The following is a description of a gene set: species: Homo sapiens Binding to a small protein activating enzyme, such as ubiquitin-activating enzyme. Human Gene Set: GOMF_SMALL_PROTEIN_ACTIVATING_ENZYME_BINDING, and this is the list of marker genes: PARK7, SAE1, SUMO1, UBE2I, UBA2